Given this list of marker genes Kcnc2, Osbpl8, Bmp4, Aoc3, Prkcd, C1qtnf12, Itln1, Car2, Gimap5, Grin1, Cox17, Gsto1, Fxyd3, Thy1, Edn3 (endothelin 3), Cftr, Acsl5, Lrrc38, Acsl6, Nherf1, Cemip, Igf1, Wnk2, C3, Oprk1, Nherf2, Snca, Rhoq, Stac, Heph, Adipor2, Adipoq, Drd4, Rgs7, Ppp3ca, Slc9a1, Slc17a8, Atp1b3, Opn3, Ednra, Calm2, Smim43, Stac3, Braf, Fxyd5, C1qtnf2, Clip3, Fgf14, Cnksr3, Gstm7, Azin2, Jph2, Pth, Galr2, Il13, Cd19, Atp1b1, Fgf13, Akap6, Rap1a, Met, Fxyd2 (FXYD domain-containing ion transport regulator 2), Pirt, Chp1, Tescl, Azin1, Ppp3r2, Akt1, Cacna1c, Gpr39, Cxcl9, Gh, Tcaf1, Scn1b, Asph, Ndufa4, Dmd, Cd4, Atp2a1, Capn3, P2rx5, Crebl2, Cxcr3 (C-X-C motif chemokine receptor 3), Kcnmb1, Fxyd7, F2, Irs2, Slc36a2, Rapgef3, Cacnb2, Akap7, Htt, Sumo1, Repin1, Stac2, Ppp3cc, Abcb1a, Grm6, Trpc3, Cxcl11, G6pd2, Trpc6, F2r, Arf1, Slc38a1, Ank2, Arhgef11, Kcnq1, Reln, Xcl1 (NCBI Gene Id 98422), Rnf207, P2rx4, Dpp6, Slc26a6, Mef2a, Wnk4 (NCBI Gene Id 69847), Trpc1, Ins2, Nfe2l2, Plcg1, Pou4f2, Agt, Sorbs1, Bak1, Strit1, Slc34a1, Cav1, Ace2, Edn1, P2ry6, Prss8, Ak1, Rasa1, Oga, Ldc1, Kcnip2, Ffar1, Gal, Gpc3, Tert, Nlgn3, Fxyd1, Gip, Calm3, Lrrc52, Fgf21, Arl6ip1, Akt2, Psen1, Drd1, Stim1, Slc7a5, G6pdx, Cltrn, Kcnc1, Kcnj2, Ms4a1, Npsr1, Wnk3, Lrrc55, Plcg2, Coa8, Hap1, Tesc, Ank3, Ehd3, Abcb1b, Pkd2, Ins1, Nr4a3, Mfn2, Fxyd4, Actn2, Klf15, Vmp1, Acsl1, Flna, Plp1, Stimate, Kcnh2, Adcyap1r1, Lhcgr, Bax, Itgb1, Fgf15 (NCBI Gene Id 14170), Nipsnap2, Atp7a, Atp1b2, Clec4b1, Ctss, Cracr2a, Gimap3, Calm1, Pdpk1, Plcb1, Nedd4l, Erfe, Slc1a2, F2rl3, Nppa, Capn10, Cacnb3, P2rx7 (purinergic receptor P2X, ligand-gated ion channel, 7), Wnk1, Erbb3, Rnasel, Irs1, Gjc2, Akap5, Insr, C2cd5, Mapk14, Cacna1d, Stim2, Dbi, Casq1, Lcn2, Ano6, Atpsckmt, Ppp3cb, Ocln, Fxyd6, P2rx1, Ptpn11, Hspa2, Abl1, Bdkrb1, Nos1, Lrrc26, Aplnr, Gper1, Sri, Adrb2, Cx3cl1, Kcne1, Adrb1, Agtr1a, Ikbkb, Cxcl10, Ifng, Erbb4, Kcne5, Appl1, Amigo1, Akap9, Ppp3r1 (protein phosphatase 3, regulatory subunit B, alpha isoform (calcineurin B, type I)), Prkci, Trdn, Ntsr1, here is a description of the gene set: Mouse Gene Set: GOBP_POSITIVE_REGULATION_OF_TRANSMEMBRANE_TRANSPORT Any process that activates or increases the frequency, rate or extent of the directed movement of a solute from one side of a membrane to the other. studied in species Mus musculus